Given this list of marker genes NRROS, CORO2A, VILL, ARSB, CYRIA, LRG1, CD244, LY86, WDR45B, SCAMP5, GADD45B, STAT4, TAPBPL (TAP binding protein like), CD300A, DGKG, SOCS3, NRP1, TMED3, PDE2A, TEC, APPL1, DIRAS2, SELENOP, IL11RA, VAV1, BCL6, LRP1, FUT7, TGFBR2, PADI2, MBOAT1, TRIM45 (NCBI Gene Id 80263), ETV6, CD34, CORO1A, HIP1, PI16, MGAT5, MET, AMN1, PAM, CCR1, MCF2L, CA12, DYNLT2B, RNASE6, EBI3, MLXIP, C8orf58, PXYLP1, SMAD1, ARID5A, RDH12, NAPSA (NCBI Gene Id 9476), ITIH5, TESK2, CDK14, SRC, BTD, IL6ST, IQGAP2, CDS1, EEIG1, KIFC3, FKBP1A, ITPRIPL2, RPS6KA2, ANO6, ACVR1B, RNASE4, PTPRC, APPL2, ZNF706 (NCBI Gene Id 51123), LRFN4 (leucine rich repeat and fibronectin type III domain containing 4), SLC26A6, SELENON, DGAT2, ELANE, SLC9A5, ARHGEF18, KLK8, PSTPIP1, CDK18 (NCBI Gene Id 5129), PPP1R3D, ARHGDIB, WFS1, CCDC122, DIAPH2, ENO1, CKAP4, CAMK2G, B4GALNT1, TBC1D15, ALAS1, TLR4, ELMO1, TMED10, INPP4A, PPT1, PGAM1, CHD3, BOK, SPP1, UGGT1 (NCBI Gene Id 56886), XBP1, RGS18, FBP1, C19orf12, HM13, CLEC7A, ST8SIA4, NPL, PLPP2, SLC44A2, DENND1C, ICAM1, FAH, NCF2 (neutrophil cytosolic factor 2), CARD10, EDEM2, LAMTOR4, DOCK2, B4GALT5, AJUBA, NKG7, TUBB6, BEX1, CD37, SESTD1, DUSP2, SYT2, NUAK2, PCDHA11, DAB2IP, OSBPL8, HMOX2, PTPN22, SEM1, CLEC11A, CMTM7, TRAM2, RAPH1, PTGER2, EDEM1, CCR2, PARP8, MSRB1, RAB34, HSD11B1, IQGAP1, MGST2, TSPAN5, RAB3D, TMEM141, GM2A, EGLN3, SLC16A7, RCSD1, VIM, ZNF608 (NCBI Gene Id 57507), TTC39A, RASSF4, CYP27A1, RAC2, ITGAL, UBE2W, MICU1, ANKRD63, CYBA, TNFAIP1, SH3PXD2A, LITAF, ISLR, ELK3, SH3BP5, PGK1, EBPL, VEGFC, TREM1, MITF, COTL1, BFAR, TRIM14, TFEC, LTBP3, TMBIM1, HEXA, MYO1G, CRYBG3, CELSR1, SHMT1, MSRA, SORBS3, AS3MT, PYCR1, SPNS3, ARHGAP25 (Rho GTPase activating protein 25), TRIO, SMPDL3B, CALML4, here is a description of the gene set: from publication Costello P, Nicolas R, Willoughby J, Wasylyk B, Nordheim A, Treisman R (PMID 20554967) Human Gene Set: GSE21546_SAP1A_KO_VS_SAP1A_KO_AND_ELK1_KO_ANTI_CD3_STIM_DP_THYMOCYTES_DN Genes down-regulated in double positive thymocytes stimulated by anti-CD3: ELK4 knockout versus ELK1 and ELK4 knockout. Removal of the transcription factor SAP1a member of the Ternary Complex Factor (TCF) group of transcription factors which in conjunction with Serum Response Factor (SRF) has been shown to have a profound effect on positive selection in the thymus. When another TCF Elk1 is knocked out in mice there is no effect on positive selection unless it is on a Sap1a KO background where the phenotype is very severe. We have stimulated isolated double positive T cells (DPs) with anti-CD3 to mimic positive selection and compared basal and stimulated transcription across the four genotypes to discover the downstream targets of Sap1a involved in positive selection. species: Homo sapiens